Given this list of marker genes NMD3, ZNF655, DCTN4, PRAG1, H2BC21, CLIP4, CITED2, GPRC5A, CCN2, DYNLRB1, CCND1, CPA4, ZNF614, SH3BP4, LACTB, ITGB8, TOB2, APPL2, SERPINE1, EHD3, PMEPA1 (prostate transmembrane protein, androgen induced 1), PPFIBP1, here is a description of the gene set: Cluster 2: genes down-regulated by RB1, CDNK2A, and one of the E2Fs (E2F1, E2F2, or E2F3). Human Gene Set: VERNELL_RETINOBLASTOMA_PATHWAY_DN from publication Vernell R, Helin K, Müller H (PMID 12923195) studied in species Homo sapiens Deregulation of the retinoblastoma protein (pRB) pathway is a hallmark of human cancer. The core members of this pathway include the tumor suppressor protein, pRB, which through binding to a number of cellular proteins, most notably members of the E2F transcription factor family, regulates progression through the cell division cycle. With the aim of identifying transcriptional changes provoked by deregulation of the pRB pathway, we have used cell lines that conditionally express a constitutively active phosphorylation site mutant of pRB (pRBDeltaCDK) or p16INK4A (p16). The expression of pRBDeltaCDK and p16 resulted in significant repression and activation of a large number of genes as measured by high density oligonucleotide array analysis. Transcriptional changes were found in genes that are essential for DNA replication and cell proliferation. In agreement with previous results, we found a high degree of overlap between genes regulated by p16 and pRB. Data we have obtained previously for E2F family members showed that 74 of the genes repressed by pRB and p16 were induced by the E2Fs and genes that were induced by pRB and p16 were repressed by the E2Fs. Thus, we have identified genes as physiological targets of the pRB pathway, and the further characterization of these genes should provide insights into how this pathway controls proliferation. We show that Gibbs sampling detects enrichment of several sequence motifs, including E2F consensus binding sites, in the upstream regions of these genes and use this enrichment in an in silico filtering process to refine microarray derived gene lists.